Given this list of marker genes Trp53inp2 (transformation related protein 53 inducible nuclear protein 2), Cln3, Vps33a, Map3k7, Ubqln2, Ctsd, Sting1, Sqstm1 (NCBI Gene Id 18412), Srebf1, Rubcnl, Trp53inp1, Wdfy3, Vcp, Ap5z1, Myo5a, Bag3, Gabarap, Rnf5, Htt, Smcr8, Spata33, Sptlc1, Mul1, Irgq, Mfn2, Spg11, Hif1a, Atg4a, Mtmr3, Trp53, Ripk2, Gba1, Pim2, Gpsm1, Ei24, Vmp1, Lrrk2, Kat5, Traf6, Epm2a, Adrb2, Parl, Iigp1c, Scfd1, Nsfl1c, Tex264, Bnip3, Mtm1, Vdac1, Ralb, Atg4b, Tafazzin, Calcoco2, Chmp7, Rab23, Fyco1, Plekhm1, Rab7, Znrf2, Psen1, Armc3, Eif2ak1, Tom1, Rab12, Chmp5, Pip4k2c, Nipsnap2, Chmp1b2, Igtp, Vps13c, Calm2, Dcn, Nupr1, Chmp4c, Supt5, Arl8b, Atg7 (NCBI Gene Id 74244), Kdr, Wdr45, Rab33b, Ubxn6, Iigp1, Fez1, Eif2s1, Wdr81, Smurf1, Trim32, Sesn3 (NCBI Gene Id 80293), Ufl1, Atg10, Pip4k2b, Optn, Stx12, Atg3, Efnb1, Tlr2 (toll-like receptor 2), Snx18, Vps4b, Snx7, Lrsam1, Snapin, Slc25a4, Csnk2a1, Dele1, Mapk3, Ubxn2b, Atg4d, Gm12185, Chmp1b, Nrbp2, Gaa, F830016B08Rik, Sesn1, Tbc1d5, Znrf1, Stbd1, Sptlc2, Calm3, Pik3r4, Mfsd8, Sec22b, Atg2a, Ufc1, Becn2, Lgals8, Atg13, Irgm1, Rnf213, Qsox1, Bnip3l, Rab33a, Fundc1, Usp36, Atp2a2, Phb2, Hdac6, Htra2, Nbr1, Nod1, Acbd5 (NCBI Gene Id 74159), Rb1cc1, Tspo, Calm1, Gabarapl1, Afg2b, Lzts1, Tsc1, Rab1a, Diaph3, Arhgap26, Atg14, Chmp2a, Tcirg1, Epg5, Cdk5rap3, Vps13d, Moap1, Slc25a5, Nod2, Lypla1, Tbc1d12, Ift88, Elapor1, Usp30, Tomm7, Ambra1, Pik3c2a, Atp13a2, Uvrag, Ap4m1, Atg16l2, Rab2a, Pjvk, Elp6, Trim13, Pdcd6ip, Scoc, Lix1l, Synpo2, Uba5, Vti1a, Snx30, Atg9a (autophagy related 9A), Plaa, Ulk2, Ikbkg, Pptc7, Tecpr1, Vps16, Abi2 (abl interactor 2), Clec16a, Fbxo7, Lix1, Zdhhc19, Map1lc3b, Tmem41b, Lrba, Sesn2, Snx4, Ogt, Pex2, Ubxn2a (UBX domain protein 2A), Chek2, Fbxl4, Atg5, Gm12250, Wipi2, Becn1, Mcoln1, Pex5, Vps41, Rab43, Pip4k2a, Vamp8, Atp6v0a1, Tigar, Aup1, Bcl2l13, Sirt1, Pik3c2b, Tbk1, Prkn, Fkbp8, Irgm2, Rab2b, Tbc1d14, Gm4841, Prkaa2, Rab1b, C9orf72, Tbc1d25, Stub1, Timm23, Larp1, Tgtp2, Rab19, Vti1b, Cttn, Ubqln1, Ilrun, Vps39, Hk2, Fez2, Retreg2, Tmem74, Poldip2, Zfyve1, Lamp2, Ube2a, Wipi1, Gabarapl2, Wdr24, Wac, Atg12 (autophagy related 12), Huwe1, Rimoc1, Zfyve26, Rufy4, Ubqln4, Ddrgk1, Snap29, Ehmt2, Ifi47, Rubcn, Ephb2, Plekhm2, Phf23, Rab3gap2, Stx17, Pikfyve, Tgtp1, Hspb8, Tmem39a, Adcy10, Rab3gap1, Chmp3, Retreg3, Pink1, Ulk3, Pafah1b2, Gm5431, Pacs2, Atg4a-ps, Ulk1, 9930111J21Rik1, Wdr45b, Chmp6, Nipsnap3b, Yod1, Ift20, Snf8, Rnf41 (ring finger protein 41), Rnf31, Gnai3, Dnm1l, Dnajc16, Snx14, Atm, Pik3c3 (phosphatidylinositol 3-kinase catalytic subunit type 3), Tsc2 (TSC complex subunit 2), Chmp2b, Atg101, Mtor, Chmp1a, Chmp4b, Atp5if1, Il4, Atg2b, Rnf186, Atg4c, Npc1, Map1lc3a, Nipsnap1, Hdac10, Retreg1, Atg16l1, Atg9b, Spart, Arfip2, Ufm1, Fbxw7, Emc6, Cers1, Elavl1, Sh3glb1, Hmox1, Cdc37 (cell division cycle 37), Vps4a, Gsk3a, here is a description of the gene set: The autophagic process that proceeds via the formation of an autophagosome. studied in species Mus musculus Mouse Gene Set: GOBP_MACROAUTOPHAGY